Given this list of marker genes RPL7L1, GLCCI1, CNTN3, MT-TT, LERFS, POTEH, LRIF1, TRAV10, MT-TP, RABGGTB, MT-ND6, BLOC1S1, UQCRBP2, SLCO3A1, BNIP3P8, RNU6-1, MT-TF, USP17L18, RPS23P5, GAS1RR, METTL15, ZNF521, ALG1, SSBP3P5, LINC01596, RNA5S17, INTS2, CTSA, MIR5002, LINC01571, NBPF1, USH2A, AUNIP, HTR1A, RPL7AP39, LINC01570, WASH3P, XKR4-AS1, LINC02372, ENSG00000253593, ALG10B, CXCL12, MTCO3P12, TSR3, MT-TE, TMEM68, MT-RNR1, ROCK1P1, WASHC2C, ZNF572, PMS2CL, PCP4, ITGA7, SLC14A2, SPOCK1, TRAV5, RN7SKP26, ENSG00000256286, TRAV13-1, CEP170, ASTN1, GNPTG, OR2A1-AS1, SNRPD2P2, TRGV5P, MT-CYB, NAGPA, NEURL2, FRG1EP, RNA5SP60, FAM21FP, LAMP1, LINC02684, LINC02888 (NCBI Gene Id 102659288), here is a description of the gene set: Human Gene Set: SMCHD1_TARGET_GENES from publication Yevshin I, Sharipov R, Kolmykov S, Kondrakhin Y, Kolpakov F (PMID 30445619) studied in species Homo sapiens